The following is a description of a gene set: species: Mus musculus Mouse Gene Set: GOBP_REGULATION_OF_IMMUNE_SYSTEM_PROCESS Any process that modulates the frequency, rate, or extent of an immune system process., and this is the list of marker genes: Gpr171, Sit1, Dusp22, Epo, Zbtb25, Trim30c, Dicer1, Acin1, Pparg (peroxisome proliferator activated receptor gamma), Lrrc14, Vav3, H2-DMa, Hcar2, Pira13, Wnt3a, Slfn1, Dapk2, Phpt1, Kir3dl2, Fpr1, Btn2a2, Gbp5, Nckap1l, Pcbp2, Nlrc3, Pdcd1lg2, Crkl (v-crk avian sarcoma virus CT10 oncogene homolog-like), Ccl1, Aqp3, Calr, Ins1, Myo18a, Rigi, Hspb1, Ube2n, Zpbp2, Ap1g1, Il12b (NCBI Gene Id 16160), Tacr1, Il34, Btrc (beta-transducin repeat containing protein, NCBI Gene Id 12234), Tlr6 (NCBI Gene Id 21899), Cxcl17, Hk1, Trim62, Ptpn22, Nr1h4, Kitl, Gbp7, Angpt1, Srebf1, Chst4, Gpld1, Aurkb (NCBI Gene Id 20877), Prkcz, Dcstamp, Smarcd2 (SWI/SNF related, matrix associated, actin dependent regulator of chromatin, subfamily d, member 2), Zfp1006, Ada, Fosl2, Csnk1a1, Cactin, Fes, H2-Q7, Lrfn5, Mad1l1, Mmp28, Foxn1, A2m, Pglyrp1, Cd300e, Duxbl1, Irgm2, Il1a, Arid2, Gnrh1, Zc3hav1, Banf1, Lypd10, Ep300, Sin3a, Plcl2, H2-D1, H2-M3 (NCBI Gene Id 14991), Clec2i, Fcna, Sppl2a, Arid1a, Map3k7, Kat6b, Cd55, Washc4, Ripk2, Rela, Il6, Efnb2, H2-M2, Trim3, Stat5b, Dhps, Sval3, Tsc22d3, Gfi1b, Xcl1, Rac1, Pibf1, Nono, Gsk3b, Paf1, Skint3, Pbrm1, Klhl25, Gfi1, Rassf5, Trim15, Nr4a3, Btnl4 (NCBI Gene Id 81496), Lrrk2, Actb, Cd3e, Akirin1, Fut9, H2-M11, Nsd2, Inpp4b, Zc3h12d, Tec, Rnf31, Ceacam1, Milr1, Cnr1, Smpdl3a, Ythdf2 (NCBI Gene Id 352969), Pde4d (phosphodiesterase 4D, cAMP specific), Polr3f, Cmtm3, Bax, Mmp9, Pglyrp2, Sarm1, Pla2g10, H2-Ea, Irf1, Sdc4, Ube2k, N4bp1, Zbtb33, Cd86, H2-Q1, Lbp, Cd300ld2, Tlr13, Gm12250, C4bp, Timd2, Lime1, Cd47, Calhm2 (NCBI Gene Id 72691), Spon2, Vegfb, Tgfb1, Pspc1, Tspan32, Mcub, Ikzf3, Cd84, Smad3, Ccl7, Lgmn, Ms4a1, Slc11a1, Il20, Cd209a, Znfx1 (NCBI Gene Id 98999), Smarcd3, Trib1, Adam17, Klhl22, Mafb, Cd300a, Sac3d1, Mturn, H2-T24, Ano6, Ikbkg, Lgals1, Bad, Nlrp4c, Jam2, Gpi1 (glucose-6-phosphate isomerase 1), Lyplal1, Thbs4, Flt3, Gcsam (NCBI Gene Id 14525), Mndal, C1s2, Cnr2, Il15ra, Gdi1, Trim30b, Inppl1 (inositol polyphosphate phosphatase-like 1), Havcr2, Ceacam20, Rtn4, Ankrd17, Plpp6, Cxcl12, Sfpq, Pf4, Ccl21d, Madcam1, C4a, Gpam, Pecam1, Cnot4, Zfp973, Stxbp2, P2rx7, Ncf1, Crhr1, C1qb, Klri1, Susd4, Oas1g, Tnfrsf13c, Usp9x, Nbl1, Cxcl5, Pnp (purine-nucleoside phosphorylase), Gpr55, Adcy7, Phb2, Mbl2, Lats1, Nectin4, Tob2 (NCBI Gene Id 73089), Siglec15, Lacc1, Hoxa9, Sele, Slit2, H2-K1, Trim21, Slamf8, Fcnb, Ctnnb1, Brcc3dc (NCBI Gene Id 368203), Ikzf1, Gpr31b, Ermap, Zbtb45, Nlrx1, Ctr9, Ighd, Lsm14a, Pum2 (pumilio RNA-binding family member 2), Setd1a, Serpinb9d, Trem2, Themis3, Fcgr3, Ube2j1, Mir181b-1, Cd226, Mapkapk2, Tek, Gpr108, Serpinb1a, Tbx21, Rsad2, Pcid2, Atg5, Ccl3, Tnfrsf11b, Ticam1, Rarres2, Ifi205, Ppp2ca, Lgals9, P4htm, Mospd2, Brpf3, Fpr-rs6, Sval2, Atg7, Swap70, Dock8, Il15, Aoc3, C1rl (complement component 1, r subcomponent-like), Mir125a, Cd38, Gpr17, Pde5a, Oasl1, Elp6, H2-M10.1, Cd101, Egr3, H2-M10.4, Lrch4, Tnip1, H2-Q10, Rhoh, Vegfc, Sec14l1, Polr3b, Mapk1, Crk, Lta, Stat1, Il5, C1qa, Gal, Abl2, Serpinb9h, Casp8, Cd160, Ms4a2, Irs2, Eeig1, H2-M5, Wdr41, Ap3d1, Apoe, Ifnl2, Itgb3, P2ry12, Mapk14, Usp12, Nfkbil1, Zbtb32, Ccl12, Ighg2b, A1bg, Tgfbr2, Fam76b, Irf2, Rarg, Zbtb37, Cbfb, Apc, Bank1, Ptpn11, Cadm1, Hmox1, Ifi209, Zbtb49, Ddx21, Ifi207 (NCBI Gene Id 98407), Tfrc, Prkd2, Eif2b3 (NCBI Gene Id 68862), Arf6, Myc, Adam8, P4hb, Blvra, Lst1, Ptpn6, Skint11, Ubash3b, Prmt1, Fcer1a, Zfp36, Zbtb34, C5ar1, Dnase1, Hamp, Clptm1, Cr2, H2-M10.3, Klrb1b, Ubqln1, Usp27x (ubiquitin specific peptidase 27, X chromosome), Inpp5d, Lrrfip2, Gpr18 (G protein-coupled receptor 18), Cd55b, Sva, Edn1, Bcar1, Wasl, Btnl1, Cd28, H2-M10.6, Il1r1, Smarcb1, Ivl, Lrrc17, Efnb1, Irf7, Clec12b, Tsc2 (TSC complex subunit 2), 2410137M14Rik (NCBI Gene Id 76797), Cd1d2, Ppbp, Serpinb9b, Cx3cr1, Pira1, Tac1, Pagr1a, Arg1, Apod, Trim30d, Dnm1l, Tcf3, Sema7a, Zbtb7a, Kcnj8, Ifng, Ythdf1, Pkp3, Litaf, Psg18, Ctsg, Acod1, 6030468B19Rik, Fcer1g, Igsf1, Bag6 (NCBI Gene Id 80605), Slc39a6, Fcgr1 (Fc receptor, IgG, high affinity I), Mlh1 (NCBI Gene Id 68687), Myd88, Glmn, Cd209e, Epg5, Itga4, Lgr4, Syt11, Meis2, Snx4, Pglyrp4, Pik3ap1, Fgl1, Pla2g2f, Mdk, Prkce, Otud4, Cd244a, Nploc4, Bloc1s3, Mir324, Notch2, Ascl2, Vpreb3, Pgc, Ufl1, Prelid1, Ighg2c, Psg29, Cyp26b1, Erfe, Il1rl1, Tbk1, Nlrp1a, Zfp608, Ceacam10, Itga2b, Rgcc (regulator of cell cycle), Btn1a1, Ap3b1, Oas1f, Rc3h1, Pqbp1, Sart1, Rps6ka3, Slc7a11 (NCBI Gene Id 99638), Phb1, Skint6, Oscar, Arrb2, Ing5, Plvap, Cxcr2 (NCBI Gene Id 12765), Rasal3, Fgfr3, Trim31, Fbxo7, Snca, Pld2, Rab7b, Leo1, Themis, Eif2ak4 (NCBI Gene Id 27103), Ppt1 (NCBI Gene Id 97141), Lrch1, Glul, Iapp, Slc4a2, Esr1, Fos, Sh2d1b1, Dcaf15, C8a, Naglu, Tspan6, Tnfrsf9, Fstl3, Psen1, Hps1, Il4i1, Mapkapk3, Adar, Il2ra, Il17d, Dab2ip, Tlr9, Slc8b1, Icos, Foxp1, Il7r (NCBI Gene Id 223338), Rnf41, Jag1, Cd40lg, Il13ra1, Tnf, BC037156, Capn1 (calpain 1), Hspa8, Thoc5, Dysf, Stk10, Twsg1, Ccl19-ps5, Rbm14, Pag1, Mfhas1, Pira2, Smad7, Nek7, Fut4, Lamp2, Creb1, Lamp1, Stoml2, Card14, Oas1d, Cdc73, Mst1, Spsb3, Cyp19a1, Il33, Igha, Tlr3, Ppp2r3c (NCBI Gene Id 80481), Cldn18, Stat5a, Irf3, Nr1d1, Clec12a, Nkap, Trim6, Colec12, Mkrn2, Spns2, Cxcl1, Cebpb, Timd6, Samsn1, Mif, Bpi, Trex1, Smpdl3b, Eif4e2, Ggt1, Zfp958, H60c, Mir326, Adgrf5, H60b, Oas1h, Nppc, Tmem102, Zbp1, Oas1c, Sos1, Myo1f, Fgr, Eif6, Slc19a1 (solute carrier family 19 (folate transporter), member 1), Bcr (NCBI Gene Id 71258), C7, Tifab, Gabpa, Trim27, Skint2, Dnase2a, Cd300ld3, Rac2, Defb25, Ulbp1, Ctla4, C9, Zp3r, Pdgfd, Kat2a, Trim30a, Wnk1, H2-Eb2, Zmiz1, Nr5a2, Gpatch3, Clec4b2, Ccl19-ps3, Cfhr4, Gps2, Azgp1, Tespa1, Inhba, Nme1, Mynn, Hmgb1, Washc1, Tnfsf13b, D1Pas1, Fbxw7, Kcnk18, Tescl, Scimp, Ankle1, Cnot7, Erbb2, Lef1, Cxcl13, Arg2, Traf6, Cd320, Usp15, Gimap5, Prdx2, Esrra, Serping1, Dhx33, Adam10, Ctsc, Cfp (complement factor properdin, NCBI Gene Id 18636), Cd300lf, Zbtb1, Il7, Ccr1l1, C4b, Dnaja3, Mul1 (mitochondrial ubiquitin ligase activator of NFKB 1), Tcta, Ror2, Pum1, Tkfc, Tsc22d1, Pik3cb, Slc39a10, Zfp131, L3mbtl1 (L3MBTL1 histone methyl-lysine binding protein), Ccl21a, Grb2, Tap2, Csf1r, Twist2, Ccl21f, Nfam1, Ezr, Ctsh, Csf3, Gpx2, Entpd7, Usp17le, H2-DMb1, Tcim, Plcg2, Cd44, Grn, Rnf34, Btnl2, Tlr4, Braf, Pkn1, S100a8, Tnfsf4, Riok3, Aplf, S100a14, Ddx60, Smarca2, Casp4, Rhoa, H2-T15, Pip, Itgam, Cd59a, Psg22, Mertk, Scrib, Hoxb8, Nectin2, Lcp2, Sftpd, Ppp3cb, Ednra, Lat2, Hif1a, Ifnb1, Hmgb2, Rbm15, Nlrp1b (NLR family, pyrin domain containing 1B), Prxl2a, Mapk8ip1, Gp6, Smarcd1, Kcnn4, Mcu (mitochondrial calcium uniporter), Rin3, Twist1, Tirap, Vsir, Btk, Cd40, Tfe3, Trim32, Cd37, C1ra, Il18, Atg9a, Anxa1, Il16, Dusp10, Actl6a, Polr3g, Lilra6, P2rx4, Tnfsf11, Vnn1, Rps3, Gigyf2, Shld1, Oas1a, Dlg5, Aire, Exosc6, Pde4b, Fyb2 (NCBI Gene Id 242594), Shpk, Clnk, Gbp2, Cd177, Selenos, Nmi, Il23a, Shb, Jak2, Sphk2, Cd1d1, Irak3, Vegfd, Mapk3, Nfkbiz, Ifi204, Bdkrb1, Cul4a, Dennd1b, Ins2, Cd74 (NCBI Gene Id 16149), Mad2l2, Cd14, Pik3cd, Alox15, Lypd11, Siglecg, Cebpa, Skint4, Smarce1 (NCBI Gene Id 74752), Prdm1 (NCBI Gene Id 12142), Ifi214, Ddrgk1, Dusp3, Mzb1, Irf4, Cep63, Treml4, Olfm4 (olfactomedin 4), Cd27, Mitf, Otulin, Fas, Marchf7, Lat, Fosl1, Rab11fip2, Tlr8 (NCBI Gene Id 170744), Spi1, Cdkn1a (cyclin dependent kinase inhibitor 1A), Pla2g2a, Il2rg (NCBI Gene Id 16186), Bid, Tmem126a (NCBI Gene Id 66271), Tigit (T cell immunoreceptor with Ig and ITIM domains), Masp2, Mtus1, Adora3, Gata2, Reg3g, Hcfc2, Lgals8, Mir301, Cd274, Cd300ld4, Gata1, Aars2, Xrcc6, Zfp3, Tyro3, Lilrb4b (NCBI Gene Id 14727), Mbl1, Sh2b2, Il23r, Ifi213, Sfn, Irf5, Zdhhc18, Ccl24, Zdhhc9, Mpl (NCBI Gene Id 17480), Tarbp2, Ptger3, Cacnb3, Sox9, Ephb6, Ipo5, Tmem176b, Mir223, Galnt2 (NCBI Gene Id 14424), Ifih1, Oas3, Eif2b5, Myo1g, Nme2, Hsf1, Car2, Rorc, Gcnt1, Pianp, Siae (NCBI Gene Id 22619), Pycard, Chst2, Stat3, Runx1, Tnfrsf14, Skint10, Hsp90aa1, Dnase1l3, Polr3c, Cd69, Rftn1, Clec4d, Vegfa, Tjp2, Wnt5a, Ppp6c, Nlrp10, Pram1, Smcr8, Nr1h3, Cdc37, Mef2c, Fyb1, Nfe2l2, Rbp1, Phf10, Ccr6, Mmp12, Znrf1, Tnfsf13, Grem1 (gremlin 1, DAN family BMP antagonist), Serpinb9g, Tnfrsf13b, Brd2, Ccl21b, Malt1, Trim25, Jund, Tab1, Rbp4, Calhm6, Serpine1, Mpp1, Flt3l, Gata3, Nfatc2, Trem3, Sos2, Gbp2b, Patz1, Mtor, Nck2, Ndfip1, Atp11c, Nfkbid, Pla2g4a, App, Dll1, Hcst, Kars1, Clec4n, Ripor2, Prkar1a, Ifi35, Aif1, Brd4, Cd96, Sppl3, Ifi211, Meaf6, Sirt1, Ighm, Lilra5, Ppl, Dppa1, Thy1, Spta1, Cyba, Il12a, Atad5, Gpsm3, Runx3, Snai2, Otud5, Psmb4, Rbfox2, Pou4f2, Clec2d, Kat6a, Gm15441, Cd59b, H2-M10.2, Wnt10b, Gpr33, Stmp1, Orm2, Pja2, Pgf, Pten, Cd6, Tifa, Stap1, Ptgs2os, Bloc1s6, Bcl6b, Ambra1 (autophagy/beclin 1 regulator 1), Gli3, H2-Ob, Aim2, Ighg3, Itgb2, Igf2, Cd22, Ihh, Eif2b4, C1qc, Tasl (NCBI Gene Id 71398), Cd300ld, Cib1, Cd300c2, Col3a1, Inava, Krt1, Cd36, Lmo1, Hc, Cdk6, Il36b, Sh2b3 (SH2B adaptor protein 3), Sox4, Nlrp3, Tyrobp, Cd276, Mia3, Nlrp4a, Tnfaip8l2, Med1, Rora, Adipoq, Tlr2, Stat2, Usp38, Lrrc19, Csf1, Shld3, Nlrc4, Fam3a, Orm3, Nf1, Trim12c, Bst2, Cptp, Ptafr, Ffar3, Ffar2, Hrg, Prkch, Rcor1, Cblb, Tmem178, Ccr2, Zcchc3, Acvr1b, Ccl19, Skint8, Npy, C5ar2, Atg12, Cd46, Tslp, Evi2, Ighe, Ubr2, Ccl2 (C-C motif chemokine ligand 2), Fbxl2, Cd8b1, Lrrc32, 5730507C01Rik, Ninj1, Fpr2, Zbtb6, Tmem131l, Mavs, Bcl10, Pla2g3, Cfd, Slc7a2, Oas1b, Abr, Ccl9, Il13ra2, Faxdc2, Rb1, Ccl25, Sash3, Abhd17a, Enpp3, Peli3, H2-Eb1, Ptk2, Trp53bp1, Kdm1a, Ifi203-ps, Ccr7, Irgm1, Psen2, Kat5, Ecsit, Fer, Klrc1, Mir150, Hoxa7, Fanca, Lrp8, Atm, Cdkn2a, Trp53, Plekha1, Cd5l, Trim5, Jak3, Pigr, Med23, Prkcb, Mog, Pla2g2d, Fpr-rs7, Ifi206, Nedd9, Zeb1, Skic8, Sox13, Klre1, Hsph1, Clec2g, Unc13d, Vcam1, Fcgr4, Sh2d1b2, Nrarp, Asxl2, Nlrp4b, Park7, Cx3cl1, Padi2, Klf13, Cfh, Bpifb1, Rhbdd3, Rasgrp1, Fam3d, Erbin, Lipa, Rnf144a, Havcr1, H2-T3, Hexim1 (NCBI Gene Id 78504), Rps19, Bmp4, Pim1, Klhl6, Il27, Skint7, Src, Stk39, Ttll12, Znrf4, Gpr137, Klrc3 (NCBI Gene Id 58179), C3, Rasgrp4, Scin, Cpt1a, Kcnk13, Ifi203, Rab29, Prkca, Igtp (NCBI Gene Id 16145), Skint5, Thbs1, Pla2g5, Cd68, Ifi208, Sh3rf1, Oxsr1, Plscr2, Ppargc1b, Tmem64, Fcrlb, Scgb1a1, Klrb1, Meis1 (Meis homeobox 1), Trim11, Ccl21e, Usp46, Cgas, Hmgb3, Zap70, Igfbp2, Cd24a, Klrb1c, Ocstamp, Klk5, C1rb, Nfkb1, Gnas, Traf3, Tlr11, Rabgef1, Cd19, Il1rl2, Tnfsf14, Traf3ip3, Epx, Dusp1, Stk11, Skap1, Kir3dl1 (NCBI Gene Id 245616), Adora2a, Gp1ba, Klrb1f, Fshr, Rac3, Zfp683, Apcs, Akirin2, Npy5r, Itgb2l, Fut7, Fcgr2b, Jam3, Fpr-rs4, Ankrd54, Zfp609, Sox11, Slc7a1, Tril, Dtx4, Camk1d, Crp, Ceacam2, Eif2b2, Mettl3, Ccl19-ps6, Cd4, Foxp3, Kmt5c, Adtrp, Il17a, Gkn2, Chuk, Nagk, Slamf1, Mefv, Ephb4, Foxj1, Gas6, Slc4a1, Dhx9, Nod2, Sting1, Vamp8, Pms2, Sirpa, Serpinb9e, Kmt5b, Hspa4, H2-M1, Ltf, Ubash3a, Thpo, Vav2, Ythdf3, Sppl2b, Lif, Pias3, Prlr, Ttbk1, Usp50, Tmbim6, Hcls1, Zfp35, Zbtb12, Rnf170, Csf3r, Prkdc, Pdpk1, Zdhhc4, Zfp580, Zfpm1, Fbn1, Tnfrsf4, Lyst, F2rl1, Ywhae, S100a9, Hpx, Msn, Brd1, Stat6, Fgl2, Klrd1, Gpr137b, Plcg1, Tap1, Gimap3, Tyk2, Tnfsf18, H2-Aa, Fpr3, Traf2, Cd83, Socs5, H2-T22, Serpinb9f, Pik3r1, Trpm4, Btnl9, Tnfrsf21, Gfer, Eif2ak2, H2-Ab1, Rassf2, Tox, Mapk8, Nos2, Ikbke, Gsdme, Parp14, Supt6, Nras, Gab2, Ccdc88b, Pilrb1, Ywhaz (tyrosine 3-monooxygenase/tryptophan 5-monooxygenase activation protein, zeta polypeptide), Ppp3ca (protein phosphatase 3, catalytic subunit, alpha isoform), Gprc5b, Cd9, Slc15a3, Hspa9, Kit (NCBI Gene Id 16590), Il3, Tal1, Pvrig, Rbm47, Slamf6, Tlr12 (NCBI Gene Id 384059), Fpr-rs3, Ptn, Ptprd, Csk, Panx1, Raet1e, Smim30 (NCBI Gene Id 97293), Zc3h8, Selenok, Tlr7, Klk7, B2m, Efnb3, Lag3, Nlrc5, Ddx3x, Zfp335, Tlr1, Stx7, Ccr1, Icosl, Ogt (NCBI Gene Id 77137), Ripk3, Apoa2, Btnl6, Itga2, Evpl, Drosha, C9orf72, Blnk, Socs6, Edn2, Ptprs, Blm, Rc3h2, Cxcl14, Matr3, Appl2, Slc46a2, Timd5 (T cell immunoglobulin and mucin domain containing 5), Cyld, Ncr3-ps, Otop1, Klri2, Cd99l2, Alpk1 (NCBI Gene Id 71481), Nlrp4e, Senp1, Psma1, Ticam2, Sh2d1a, Zbtb7b, Ifnl3, Gper1, Cd79a, C3ar1, Ptger4, Ecm1, Abl1, St3gal4, Nop53, Zdhhc12, Nlrp4f, Prnp, Rnf125, Sirt2, Xbp1, Cnn2, Ets1, Creb3, Peli1, Igf1 (insulin-like growth factor 1), Laptm5, Adrm1, Pithd1, Ptk2b, Fcmr, Xrcc5, Orm1, Fzd5, Mmp14, Pglyrp3, Itgal, Rptor, Nfkbia, Trim41, Msh2, Clec7a, Tgfb3, Btla, Jun, Btnl12, Ccl20, Cftr, Zbtb26, Prkaa1, H2-T5, Hfe, Mstn, Il12rb1, Ptpre, Prkd1, Tax1bp1, Casp6, Tcf7, Htr2a, Slc15a4, Ptprc, Ephb2, Dhx58, Fn1, C2, Pirb, Acvr2a, Ahr, Dnajb9, Tmigd3, Opa1, Sval1, Klrc2, Ypel4, Wdfy1, Chrnb2, Cd81, Acp5, Cd300c, Card9, Cd2ap, Zbtb39, Cr1l, Clec4g, Il4ra, Il17f, Foxo3, Brd7, Mmp8, Becn1, Abcb10, Serpinb9c, Cd300lb, Casp3, Rara, Lilrb4a, Crlf2, Tnfrsf11a, Tomm70a, Oas1e, Rnf135, Paxip1, H2-Q2, Lck, Zfp36l2, Zp3, Clec4e, Mysm1, Selp, Lyar, Lyn, Socs1, Qki (quaking, KH domain containing RNA binding), Pawr (NCBI Gene Id 76427), Masp1, Ddx1, Ccl5, Muc5b, Il6st, Cd5, Il1b (NCBI Gene Id 16176), Ufd1, Fcer2a, Fshb, Cd209c, Lats2, Lair1, Hmces (5-hydroxymethylcytosine (hmC) binding, ES cell specific), Lax1, Tapbpl, Bcl2a1d, Hspa1b, Nlrp6, Prg2, Lox, Ctla2a, Zdhhc1, Cd8a, Pik3r6, Akt1, Was, Pou4f1, Tnfrsf1b, Dhx36, Trpv4, Clpb, Hax1, Mir181b-2, Lep, Coro1a, Sphk1 (NCBI Gene Id 66122), Tnfaip6, Cfb, Unc93b1, Zbtb46, Flot2, Lpxn, Actl6b, Brcc3, Dlg1, Dgkz, Ccl19-ps4, Polr3d, Fyn, Slamf7, Klrk1, Themis2, Tmem176a, Fbxo38, Ccl28, Loxl3, Gpnmb, H2-Q6 (histocompatibility 2, Q region locus 6), Il2, Mr1, Ripk1, Rap1a, Hras, Hspd1, Perp, Tgfb2, Tarm1, Cd79b, Axl, Gata6, Zbtb24, Tnip3, Sla2, Cxcr3, Slc15a2 (solute carrier family 15 (H+/peptide transporter), member 2), Cfi, Slc22a13, Pck1, Prkcq, Nppa, Bmi1, Zdhhc5, Trat1, Tbc1d10c, Fam210b, Sfrp1, Dlk1, Fadd, Trem1, Ccn3, Vav1, Fcho1, Phf11a, Il27ra, Usp29, Gramd4, Drd2, Cd80, Card11, Sqstm1, Evi2b, Ildr2, Cd200, Trim12a, Rbck1, Rif1, Zbtb20, Trim56, Mill1, Raet1d, Ldlr, Kat7, Itpkb, F7, Tnfaip3, Rag1, Pira12, Cst7, Pla2g7, Cartpt, Cyrib (NCBI Gene Id 76270), Dpp4, H2-M9, Zbtb2, Il21, Fgf10, Trav7-2, Crtam, Elf1, Cmklr1, Zbtb14, Fcrl5, Rapgef1, Gpr68, Phlpp1, Exosc3, Emilin1, Zfp36l1, D6Wsu163e, Bcl2, C6, Irak2, Vtcn1, Card10, Ereg, Nod1 (nucleotide-binding oligomerization domain containing 1), Ldb1, H2-T13, Dapl1, Appl1, Klf10, Ctnnbip1, Lgals3, Sh3kbp1, Znhit1, Parp1, Ywhag, Ncr1, Tlr5, Gpr15lg, Smarcc1, Cfhr1, Arid5a, Il10, Adora1, Flot1, Sox12, Xiap, Hoxa5, Adk, Tafa3, Pvr, Vsig4, Itch, C1s1, Fancd2, Shh, H2-Oa, Tnip2, Il18rap, Rag2, Klrh1, Smarca4, Smarcc2, H2-M10.5, Bst1, Gpr183, Serpinb9, Muc4, Itk, H2-T23, Parp3, Atat1, Trafd1, Stxbp1, Cacnb4, C8g, Rnf115, Usp18, Dcst1, Lyve1, Carmil2, Myb, Clcf1, Slc9b2, Lmo2, Il4, Eif2b1, Icam1, Ptpn2, Shld2, Parp9, Mark4 (MAP/microtubule affinity regulating kinase 4), Isg15, Pomc, Adora2b, C1qbp (NCBI Gene Id 28127), Klrb1a, H2-Q4, Gbp3, Tnfsf9, Cuedc2, Hlx, C8b, Letmd1, Ighg1, Nck1, Tnfrsf18, Plcb1, Prdm16, Ccl19-ps1, Smpd3, Pdcd1, Stx4a, Edn3, Cxcl10, Bcl6, Casp1, Il20rb, Il18r1, Btnl10, Skint9, Gpx1, Il13, Blk, Id2, Samhd1, Bmx, Syk, Cd209d, Ager, Cfhr2, Smap1, Hes1, Cd200r1, Ly96, Gdf15, Skint1, Plscr1, Tff2, Foxf1, Irak1 (NCBI Gene Id 16179), Zc3h12a, H2-DMb2, Zdhhc3, Spn, Rnf185, Colec11, Sell, Khdrbs1, Ddx39a, Ccdc134, Itpripl1, Dtx1, Bmyc, Cav1, Colec10, Ptprj, Adcyap1, Cd247 (CD247 antigen), Elane, Apoa1, Ido1, Tesc, Txk